The following is a description of a gene set: species: Homo sapiens from publication Chen Y, Wang X (PMID 31504780) Genes predicted to be targets of miRBase v22 microRNA hsa-miR-3913-3p in miRDB v6.0 with MirTarget v4 prediction scores > 80 (high confidence targets). Human Gene Set: MIR3913_3P, and this is the list of marker genes: SUZ12, PKIA, ADAM23, PARM1, NFIL3, SHISA7, PPP1CB, MAGI3, SPTLC1, GUF1, ANAPC7, PNISR, IMPA1, MRPL1, TXNDC16, ESCO2, ZNF790 (NCBI Gene Id 388536), SEMA6A, RAP1GDS1, SRSF1, MIER1, DCC, RIPK4, SMAD2, CMTM6, KCTD4, UBE2I, FEM1B, SLC5A12, CLOCK, EMC7, NOTCH2, AIG1, MXI1, KYNU, LRRC7, PRRC2C, ALOX5AP, PKP1, GNG12, KIF5A, MEGF10, RGS18, NRIP1, DUSP4, RPP30, TRPA1 (transient receptor potential cation channel subfamily A member 1), CCDC141 (coiled-coil domain containing 141), C3orf62, SNX3, MNS1, DDX3X, KIAA1549, B4GALT3, FAM117B, EFCAB11, GPC6, DCAF13, TMEM117, MS4A18, PTPN1, SLC9C2, ANKRD49, ADAM28, CDK1 (NCBI Gene Id 983), UBE4A, PDS5B, ANKRD28, RAB3C, NUFIP2, SCUBE3, ATP1B3, TTN, PPP1R9A, UPF3B